Given this list of marker genes LEISA1, LINC01561, MAGEE1, STMN2, PIRT, BCORP1, SNPH, TOB2P1, PPP2R5B, CDK13-DT, YWHAH, SULT4A1, PRPH, PDE6B-AS1, CHRM1, SCN2B, RNU7-110P, RNU6-1099P, KRT18P11, FKBP1B, EEF1DP4, ENSG00000236754, NPY2R, TUBB3 (tubulin beta 3 class III), LINC02636, ENSG00000261924, FBXO30, SLC5A7, ELOVL3, MKRN5P, UCHL1, PATJ-DT, NCAM1-AS1, SLC7A14, LINC02735, ENHO, ENSG00000255326, NAP1L5, CPMER, ENSG00000272008, HEPHL1, RNU6-1237P, NECAB2, KBTBD11-OT1, PERPP2, RN7SL784P, BZW1-AS1, ASTN2-AS1, YBX1P1, PCOTH, ALKBH3-AS1, VAT1, FSD1, LINC03056, RNA5SP383, RPL8P3, RNU6-672P, VN1R108P, CFHR5, FAM200C, LINC01918, HSPD1P1, C17orf107, NEFH, FAM167A, MTX1, TUBB, RUSC1, RNA5SP464, GNAO1, HAGLROS, TMEM59L, CTNNA2-AS1, OPA1-AS1, HLX-AS1, TMEM271, FST, NCS1, YWHAG, NEIL2, TMEM151B, CCDC184, BEND6, SEPTIN14P12, TUBB2A, RAB6B, RAB15, ARHGDIG, here is a description of the gene set: Human Gene Set: DESCARTES_MAIN_FETAL_VISCERAL_NEURONS species: Homo sapiens from publication Cao J, O'Day DR, Pliner HA, Kingsley PD, Deng M, Daza RM, Zager MA, Aldinger KA, Blecher-Gonen R, Zhang F, Spielmann M, Palis J, Doherty D, Steemers FJ, Glass IA, Trapnell C, Shendure J (PMID 33184181) The gene expression program underlying the specification of human cell types is of fundamental interest. The study authors generated human cell atlases of gene expression and chromatin accessibility in fetal tissues. For gene expression, the study authors applied three-level combinatorial indexing to >110 samples representing 15 organs, ultimately profiling ~4 million single cells. The study authors leveraged the literature and other atlases to identify and annotate hundreds of cell types and subtypes, both within and across tissues. Our analyses focused on organ-specific specializations of broadly distributed cell types (such as blood, endothelial, and epithelial), sites of fetal erythropoiesis (which notably included the adrenal gland), and integration with mouse developmental atlases (such as conserved specification of blood cells). These data represent a rich resource for the exploration of in vivo human gene expression in diverse tissues and cell types. Marker genes curated from the annotated cluster as represented in the Descartes Human Gene Expression During Development database.